Given this list of marker genes CYP2C8, CYP3A5, CYP1A1, CYP3A4, CYP2E1, CYP4A22, CYP3A7, here is a description of the gene set: studied in species Homo sapiens Human Gene Set: GOBP_LIPID_HYDROXYLATION The covalent attachment of a hydroxyl group to one or more fatty acids in a lipid.